The following is a description of a gene set: from publication Clasper S, Royston D, Baban D, Cao Y, Ewers S, Butz S, Vestweber D, Jackson DG (PMID 18794116) Invasion of lymphatic vessels is a key step in the metastasis of primary tumors to draining lymph nodes. Although the process is enhanced by tumor lymphangiogenesis, it is unclear whether this is a consequence of increased lymphatic vessel number, altered lymphatic vessel properties, or both. Here we have addressed the question by comparing the RNA profiles of primary lymphatic endothelial cells (LEC) isolated from the vasculature of normal tissue and from highly metastatic T-241/vascular endothelial growth factor (VEGF)-C fibrosarcomas implanted in C57BL/6 mice. Our findings reveal significant differences in expression of some genes (i.e., >or=2-fold up- or down-regulated, P <or= 0.05) that code for a variety of proteins including components of endothelial junctions, subendothelial matrix, and vessel growth/patterning. The tumor LEC profile, validated by immunohistochemical staining, is distinct from that of normal, inflammatory cytokine, or mitogen-activated LEC, characterized by elevated expression of such functionally significant molecules as the tight junction regulatory protein endothelial specific adhesion molecule (ESAM), the transforming growth factor-beta coreceptor Endoglin (CD105), the angiogenesis-associated leptin receptor, and the immunoinhibitory receptor CD200, and reduced expression of subendothelial matrix proteins including collagens, fibrillin, and biglycan. Moreover, we show similar induction of ESAM, Endoglin, and leptin receptor within tumor lymphatics in a series of human head and neck and colorectal carcinomas, and uncover a dramatic correlation between ESAM expression and nodal metastasis that identifies this marker as a possible prognostic indicator. These findings reveal a remarkable degree of phenotypic plasticity in cancer lymphatics and provide new insight into the processes of lymphatic invasion and lymph node metastasis. studied in species Mus musculus Selected genes up-regulated during invasion of lymphatic vessels during metastasis. Human Gene Set: CLASPER_LYMPHATIC_VESSELS_DURING_METASTASIS_UP, and this is the list of marker genes: THBS1, ESAM, F11R, NECTIN2, AJUBA, CXADR, CD200, HOXB5, UNC5B, LEPR, SPRY1, ENG, PDGFB, ANGPT2, EDN1, ADM, PIM1, TNC, TGFB2, TGFB3